The following is a description of a gene set: We demonstrate that the G protein Gi3 is the cellular target of the adenosine A3 receptor (A3R). By using a cell permeable peptide comprising the C-terminal end of Gαi3 fused to an importation sequence (ALL1) as a selective inhibitor of Gi3 signaling, we show that by coupling to Gi3, the A3R stimulates multiple signaling pathways in human mast cells, leading to upregulation of cytokines, chemokines and growth factors.Following contact with activated T cell membranes, endogenous adenosine binds to and activates the A3R, resulting in Gi3-mediated signaling. Specifically, the majority of ERK1/2 signaling initiated by contact with activated T cell membranes, is mediated by Gi3, giving rise to ALL1-inhibitable cellular responses. These results unveil the physiological GPCR that couples to Gi3 and establish the important role played by this G-protein in inflammatory conditions that involve adenosine-activated mast cells. We used microarrays to detail the effect of ALL1 on gene expression of HMC-1 cells activated directly by the A3 receptor, or by contact with activated T cell membranes. Genes up-regulated in HMC-1 (mast leukemia) cells: Cl-IB-MECA versus incubated with the ALL1 peptide followed by treatment with Cl-IB-MECA. Human Gene Set: GSE19888_ADENOSINE_A3R_ACT_VS_A3R_ACT_WITH_A3R_INH_PRETREATMENT_IN_MAST_CELL_UP species: Homo sapiens from publication Baram D, Dekel O, Mekori YA, Sagi-Eisenberg R (PMID 20190146), and this is the list of marker genes: FH, STX8, E2F2, PRADC1, DPAGT1, BCAT2, GPSM2, JHY, DARS2, MRPL37, TMEM97, SNUPN, TMSB15A, HIGD1A, ASNS, EIF2D, SYNGR3, TCEA2, CCDC15, FLT3LG, ATP5MG, CKLF, SLC24A3, CEP57L1, ARHGEF39, UBL4A, SNRNP25, DAXX, C3orf18, CENPE, REEP6, TRIM47, SAPCD2, FBXO44, C1RL, CEP15, IFI27L2, PAXIP1, NDUFB4, IER3IP1, GINS2, IL1RL1, CHCHD2, DHPS, SDR42E1, SPC24, AK2, KPNA2, CALU, SLCO4A1, MYL12B, CCDC28B, PBX4, NOC4L, ENSG00000291006, BTBD6, HADH, AARS1, CCNF, DCLRE1B, CDC25C, CTNNBL1, CCNQ, PLK1, ROMO1, HNRNPF, PDE6D, PSMC3IP, CDKN2AIPNL, NSDHL, PPCDC, CEP43, VCF1, PLSCR3, EIF4A3, ZNHIT1, NAA10, RNASEH2C, FARSB, COQ3, CENPO, CSNK2B, USP1, TMPO-AS1, GMPPB, UBE2L3, MRPL12, FBXO43, CHCHD7, ZNF788P, UQCC4, E2F1, KIFBP, BRCA2, EOGT, METAP2, MPHOSPH6 (M-phase phosphoprotein 6), INPP4B, MLLT11 (NCBI Gene Id 149430), INCENP, CHRNA5, LSM4, POC1A, PUSL1 (NCBI Gene Id 126789), STOML2, NUDT21, SELENOS, MTPAP, FKBPL, CAD, LSM10 (NCBI Gene Id 84967), LRR1, DHODH, NELFE, NIT2, RNF26, LYRM1, NICN1, CSTF2, LAPTM4B, ERI2, MSMO1, SNRPA, PSPH, ATP5MC3, TEX30, ZDHHC13, RRP36, E2F7, METTL3, GSS (glutathione synthetase), GARS1, MTX1, TMSB15B-AS1, CEP131, PSMD13, NET1, HNRNPD, KIF20A, RHOBTB2, TMEM177, DTYMK, FAM241B, WDR90, CLN6, C4orf46, MRPS14, C1orf131, DBF4 (DBF4-CDC7 kinase regulatory subunit), MGME1, ZNF512, DYNC2I2, DSN1, VAMP8, AQP3, VPS25, RPS27L, APOL4, TMEM242, PGBD1, FAM111B, AIFM2, RANBP1, BARD1, TTI2, UBASH3A, KIF20B, PJA1, MMAB, KNTC1, HMGXB4, RMI2 (NCBI Gene Id 116028), TOX2, COMTD1, WDR76, MTAP, GOLGA2P5, GSTZ1, GGT5, DRG1, STYK1, IMPA2, SCRN3, CEP20, C21orf58, ESCO2, TSPAN17, RAD51AP1, HMGB3, MRPL44, CMTM1, FDPS, RNF138, LIF, RASSF7, MRPS16